The following is a description of a gene set: studied in species Homo sapiens Listeria monocytogenes entry into host cells Human Gene Set: REACTOME_LISTERIA_MONOCYTOGENES_ENTRY_INTO_HOST_CELLS, and this is the list of marker genes: UBA52, SRC, CBL, SH3GL3, UBC, CTNND1, STAM, SH3GL2, SH3KBP1, UBB, CTNNB1, RPS27A, HGS, SH3GL1, EPS15, CBLL1, CDH1, MET, GRB2, STAM2